The following is a description of a gene set: Human Gene Set: GOBP_REGULATION_OF_T_HELPER_17_CELL_DIFFERENTIATION Any process that modulates the frequency, rate or extent of T-helper 17 cell differentiation. species: Homo sapiens, and this is the list of marker genes: MALT1, FOXP3, BATF, JUNB, JAK3, CD69, OPA1, NFKBIZ, EP300, MIR21, LGALS1, IL12RB1, IL12B, ASCL2, SMAD7, STAT5A, RC3H2, BRD4, NFKBID, IL23R (interleukin 23 receptor), IL2, LOXL3 (lysyl oxidase like 3), BRD2, RC3H1, IL23A, ZC3H12A, TBX21, ZBTB7B, TNFSF18